Given this list of marker genes SMAD2, SMAD3, RPS27A, UCHL5, MTMR4, NEDD8, ITGB8, ITGB3, PPP1CB, FKBP1A, LTBP1, SMURF1 (NCBI Gene Id 730332), USP15, UBA52, LTBP2, ZFYVE9, SMAD7 (NCBI Gene Id 4092), ITGB6, TGFB3, STRAP, UBC, TGFB1, UBB, LTBP4, PPP1CC, SMAD4, FBN1, LTBP3, PMEPA1, TGFBR1, STUB1, SMURF2, XPO1, ITGA8, CBL, BAMBI, PPP1R15A, ITGAV (integrin subunit alpha V), PPP1CA, FURIN, TGFBR2 (NCBI Gene Id 7048), TGFBR3, UBE2M, NEDD4L, TGFB2, ITGB5, ITGB1, here is a description of the gene set: part of: Signaling by TGF-beta Receptor Complex Reactome Pathway: TGF-beta receptor signaling activates SMADs species: Homo sapiens Binding of transforming growth factor beta 1 (TGF beta 1, i.e. TGFB1) to TGF beta receptor type 2 (TGFBR2) activates TGF beta receptor signaling cascade. TGFB1 is posttranslationally processed by furin to form a homodimer and secreted to the extracellular space as part of the large latent complex (LLC). After the LLC disassembles in the extracellular space, dimeric TGFB1 becomes capable of binding to TGFBR2. Formation of TGFB1:TGFBR2 complex creates a binding pocket for TGF-beta receptor type-1 (TGFBR1) and TGFBR1 is recruited to the complex by binding to both TGFB1 and TGFBR2. This results in an active heterotetrameric TGF-beta receptor complex that consists of TGFB1 homodimer bound to two heterodimers of TGFBR1 and TGFBR2. TGF-beta signaling can also occur through a single heterodimer of TGFBR1 and TGFBR2, although with decreased efficiency. TGFBR1 and TGFBR2 interact through their extracellular domains, which brings their cytoplasmic domains together. Ligand binding to extracellular receptor domains is cooperative, but no conformational change is seen from crystal structures of either TGFB1- or TGFB3-bound heterotetrameric receptor complexes.<br><br>Activation of TGFBR1 by TGFBR2 in the absence of ligand is prevented by FKBP1A (FKBP12), a peptidyl-prolyl cis-trans isomerase. FKBP1A forms a complex with inactive TGFBR1 and dissociates from it only after TGFBR1 is recruited by TGFB1-bound TGFBR2. <br><br>Both TGFBR1 and TGFBR2 are receptor serine/threonine kinases. Formation of the hetero-tetrameric TGF-beta receptor complex (TGFBR) in response to TGFB1 binding induces receptor rotation, so that TGFBR2 and TGFBR1 cytoplasmic kinase domains face each other in a catalytically favourable configuration. TGFBR2 trans-phosphorylates serine residues at the conserved Gly-Ser-rich juxtapositioned domain (GS domain) of TGFBR1, activating TGFBR1.<br>In addition to phosphorylation, TGFBR1 may also be sumoylated in response to TGF-beta stimulation. Sumoylation enhances TGFBR1 kinase activity. <br><br>The activated TGFBR complex is internalized by clathrin-mediated endocytosis into early endosomes. With the assistance of SARA, an early endosome membrane protein, phosphorylated TGFBR1 within TGFBR complex recruits SMAD2 and/or SMAD3, i.e. R-SMADs. TGFBR1 phosphorylates recruited SMAD2/3 on two C-terminal serine residues. The phosphorylation changes the conformation of SMAD2/3 MH2 domain, promoting dissociation of SMAD2/3 from SARA and TGFBR1 and formation of SMAD2/3 trimers. The phosphorylated C-terminal tail of SMAD2/3 has high affinity for SMAD4 (Co-SMAD), inducing formation of SMAD2/3:SMAD4 heterotrimers, composed of two phosphorylated R-SMADs (SMAD2 and/or SMAD3) and SMAD4 (Co-SMAD). SMAD2/3:SMAD4 heterotrimers are energetically favored over R-SMAD trimers. <br>SMAD2/3:SMAD4 heterotrimers translocate to the nucleus where they act as transcriptional regulators.